The following is a description of a gene set: species: Mus musculus Mouse Gene Set: CUI_T_CELL_GD_IL36A_RESPONSE_DN Cytokines mediate cell-cell communication in the immune system and represent important therapeutic targets. A myriad of studies have highlighted their central role in immune function, yet we lack a global view of the cellular responses of each immune cell type to each cytokine. To address this gap, the authors created the Immune Dictionary, a compendium of single-cell transcriptomic profiles of more than 17 immune cell types in response to each of 86 cytokines (>1,400 cytokine-cell type combinations) in mouse lymph nodes in vivo. A cytokine-centric view of the dictionary revealed that most cytokines induce highly cell-type-specific responses. For example, the inflammatory cytokine interleukin-1β induces distinct gene programmes in almost every cell type. A cell-type-centric view of the dictionary identified more than 66 cytokine-driven cellular polarization states across immune cell types, including previously uncharacterized states such as an interleukin-18-induced polyfunctional natural killer cell state. Genes negatively differentially expressed in cell type: γδ T cell upon treatment with cytokine: IL-36α in mouse lymph nodes in vivo. from publication Cui A, Huang T, Li S, Ma A, Pérez JL, Sander C, Keskin DB, Wu CJ, Fraenkel E, Hacohen N (PMID 38057668), and this is the list of marker genes: H2az2, Ankrd44, Pnrc1, Fos, Kif21b, S100a10, Cxcr4, Txnip, Itm2b, Klf6, AB124611, Arhgef1, Ncor1, Ube2h, Hcst, Clk1, Foxp1, Mxd4, Pink1, Gmfg, S100a6, Adgre5, Macf1, Tspo, Akap13 (NCBI Gene Id 76109), Ctsd, Fosb, Btg2, Itgb7, Smpdl3a, Skap1, Cd7, Mbnl1, Ski, Evl, Acp5, St3gal6, Lpar6, Dap, Saraf, Arhgap45, Tmem64, Lsp1, Ptpn18, Klhl6, Entrep3, Selplg, Il17rb, Ypel3, Pdcd4, Pbxip1, Arhgdib, Klf2, Rgcc, Egr1, Itgae, Pfdn5, Il7r, Ckb, S100a11, Rgs10, Paip2, Selenop, Faah, Hmgb2 (NCBI Gene Id 97165), S100a4, Anxa1, Crip1, Sh3bgrl3, Junb, Cdc42ep3, Il18r1, Tmem50a, Sdc1, S1pr1, Zfp36l2, Cox7a2l, Fxyd5, Emp3, Ucp2, Crlf3, Ahnak, Ubc, Pwwp3a, Bnip3l, Arid1a